The following is a description of a gene set: studied in species Homo sapiens Three innate (B1-B, NKT, CD8aaT cells) and adaptive (B2-B, CD4T, CD8abT cells) cell-types were sorted by FACS. Three biological replicates for NKT, CD4T, CD8aaT, CD8abT cells and two biological replicates for B1 and B2 cells were generated and the expression profiles were determined using Affymetrix Mu74Av2 chip. Comparisons between the sample groups allow the identification of genes differentially expressed between the innate and adaptive cell-types. from publication Yamagata T, Benoist C, Mathis D (PMID 16623764) Genes up-regulated in CD8A T cells versus B1 B lymphocytes. Human Gene Set: GSE3039_ALPHAALPHA_CD8_TCELL_VS_B1_BCELL_UP, and this is the list of marker genes: PIP4K2A, ERP44, MTMR9, RNF103, GNGT2, CTSA (cathepsin A), ZFP3, IL6ST, GBP4 (guanylate binding protein 4), EIF1AY, DIP2C, CD274, SLC43A2, DPY19L1, GATM, DDX21 (NCBI Gene Id 9188), CPSF4, GCNT2, KBTBD11, KCNK6, SELENOI, C1orf216, DIP2A, ALKBH2, ZNF846, LPXN, VKORC1, CD300A, POSTN, EIF3J, EMILIN2, ACOT11, ECE2, GFM2, NRIP1, PRDM1, UBE2N, CTSS, MRAS, TGM1, FEZ2, RND3, CD209, SAYSD1 (NCBI Gene Id 55776), CORO1C, IL15RA, HRH1, FAM43A, TMEM65, SIRT2, ANKRD37, API5, SLC35F6, EFHD2, PLA2G15, PFKL, DNAJB11, SSH3, ARSK (arylsulfatase family member K), PIGC, NSFL1C, GAB1, NEMF, MFSD1, MCCC1, RPUSD4, TMED4, PLEKHB2, TMEM87B, FYN, FKBP1B, IBTK, EHBP1, TSPYL4, SLC25A30, ITCH, TRIM46, SOAT1, SMC6, TRAF1, RCAN1, MVP, CD302, GPR35, LCP2, AFG1L, LHFPL6, RNH1, TMEM268, NCKAP1L, ZMAT3, LSG1, RGS1, TMEM126A, LXN, CD80, ARAP2, RASSF8, DNAH2, MAN2A1, RPL4, MAGT1, HEBP2, GP2, SLC49A4, SPCS2, BMF, P2RY6, SIRPB1 (signal regulatory protein beta 1), BRMS1L, GSPT1, SH2D1B, PHYHD1, BCL2A1, CHCHD10, ASB2, EPB41L3 (NCBI Gene Id 8730), CYRIA, MATK, SMAGP, ALDH1B1, RAC1, CORO2A, LPP, ACOX1, GALNT7, PTPMT1 (NCBI Gene Id 114971), PPP1R21, SERP1, KCNN4, SLC2A1, KLK8, C1orf54, RGL1, MRC1, SOCS5, IL18, JAK2, ATP6AP2, FAM135A, FCGRT, GALK2, RAB14, ANAPC16, LRP12, UBE2E3, NAB2, ELOVL5, ACLY, TRPM4, MERTK, ARL6IP4, MRPS34, DAPK1, GLUD1, P2RY14 (NCBI Gene Id 9934), TNS4, KANK3, TDRD7, ITM2C, ANPEP, FAM91A1, IFT43, BRI3BP, SLC35F5, METRNL, GNS, HS6ST1, TF, ICA1L, ITPRID2, CD93, GTF2H1, MRPS25, SLC36A1, CAPN5, MS4A6A, BATF, TMEM106A, SPRYD7, ATP7A, C2, ALG9, TMEM86A, TMCC3, CCND2, BDH1, IER3, LAG3 (NCBI Gene Id 3902), BNIP2, POLK, PROCR, NME7, PTPN1, RAB12, RSL24D1, CTSO, UFC1, RIMS3, RAP2A